The following is a description of a gene set: from publication Chen Y, Wang X (PMID 31504780) Genes predicted to be targets of miRBase v22 microRNA hsa-miR-378f in miRDB v6.0 with MirTarget v4 prediction scores > 80 (high confidence targets). studied in species Homo sapiens Human Gene Set: MIR378F, and this is the list of marker genes: FCGR1A, CHAMP1, PLCXD2, ATXN7L3B, RAN, VPS53, RPN2, PHC3, SULF1, AGK, METTL4, NKX3-1, CREBRF, WDR64, KCNIP2, KLK4, JADE3, NR2C2, OTUB2, ELAC1, PIM2, RNF168, NCAPG, AK7, TSPAN17, NHSL3, CCNI2, GPR156, NUAK2, RAB10, FLT1 (fms related receptor tyrosine kinase 1), C4orf46, CPD, ZNF124, ZFPM2, PROK2, PTGES3, NPAS4, UHRF1